Given this list of marker genes PER2, ORC6, AIRIM (NCBI Gene Id 54955), PRKG1, KPNB1, DNAJB14, CDC14A, PRKAR1A, GRIP2, ZNF468, SLC39A8, ASAP1, CHRNG, NCOA2 (NCBI Gene Id 10499), FBXL20, ADORA3, NR2F2 (NCBI Gene Id 7026), RND3, EIF4EBP3, USP46, COPS2, MAP1B, OPRK1, PAPPA (NCBI Gene Id 5069), PHACTR2, C2CD6 (C2 calcium dependent domain containing 6), ANKHD1-EIF4EBP3, HDDC3, ADGRB3, CER1, NEMP1, ATP8A1, FNIP2, RTF1, GLYAT, CSRNP3, SCN3B, PTER, KLHL15, ZNF215, CBX5, MAP3K20 (mitogen-activated protein kinase kinase kinase 20), ADH6, AVL9, TIMELESS, AGRN, SPG7, PIK3CA, VCP, KCTD13, RAB22A (RAB22A, member RAS oncogene family), ZNF266, PRCC, WASF1, VEZT, SETD5, SLC7A6, here is a description of the gene set: species: Homo sapiens from publication Chen Y, Wang X (PMID 31504780) Human Gene Set: MIR4494 Genes predicted to be targets of miRBase v22 microRNA hsa-miR-4494 in miRDB v6.0 with MirTarget v4 prediction scores > 80 (high confidence targets).